The following is a description of a gene set: species: Mus musculus Mouse Gene Set: GOBP_REGULATION_OF_TRANSLATIONAL_FIDELITY Any process that modulates the ability of the translational apparatus to interpret the genetic code., and this is the list of marker genes: Iars2, Prorsd1, Dtd1, Vars2, Aars1, Lars1, Dnajc2, Aarsd1, Iars1, Vars1, Gatc, Lars2, Yrdc, Cdk5rap1, Dtd2, Tars2, Rps5